Given this list of marker genes Pawr, Mmp24, Cxcl12, Rho, Nr2f6, Adra2a, Trpv1, Htr2a, Ano1, Arrb2, Tac4, Wdr47, Kcnk4, Tlr4, Scrn3, Cpeb3, Grik2 (glutamate receptor, ionotropic, kainate 2 (beta 2)), Disc1, Ephb1, Trpa1 (NCBI Gene Id 277328), Scn10a, Btbd9, Comt, Tac1, Adora1, Ntrk1, Opn4, Enpp1, Nrg1, Ngf, Lxn, Cxcr4, Oprk1, Scn9a, Trpm8, Prdm12, Ntsr1, Asic3, Scn11a, Calca, here is a description of the gene set: The series of events required for an organism to receive a sensory temperature stimulus, convert it to a molecular signal, and recognize and characterize the signal. This is a neurological process. studied in species Mus musculus Mouse Gene Set: GOBP_SENSORY_PERCEPTION_OF_TEMPERATURE_STIMULUS